Given this list of marker genes NPSR1, CXCL12, ATP6V0B, METTL21C, CP (ceruloplasmin), ATP6V1H, SLC4A7, CCDC22, EDN1, TMPRSS6, CASQ2, FTL, FTH1P19, SLC12A5, SLC30A5, SLC30A2, PTH1R (parathyroid hormone 1 receptor), BOLA1, ARF1, TM9SF4, CASQ1, LRRK2, CXCL9, ATP6V1A, CAV3, P2RX1, HTR2C, RGN, SLC39A10, WNK1 (NCBI Gene Id 9872), SLC4A1, CHRNA7, TMEM178A, MINPP1, EGLN1, PACS2, SLC26A3, THADA, SLC24A1, SLC4A4, SCNN1D, MAPK1, AQP11, NOL3 (nucleolar protein 3), SLC4A3, RNASEK, CHERP, CDH5, SLC4A2, ABL1, ABCB7, SCNN1G, MCOLN1, ITPR1 (inositol 1,4,5-trisphosphate receptor type 1), TUNAR, CCL21, CACNB4, HEPHL1, LIME1, GP1BA, ATP6AP1, FATE1, WBP2NL, DRD5, ANKRD9, CYBA, CLIC2, SPPL2C (NCBI Gene Id 162540), ATP13A1, BAX, EDNRA, BOLA3 (NCBI Gene Id 388962), RMDN3, VDR, PRKCE, TRPC7, CCR5, SLC39A14, ATP6V1B1, SLC9C1, FASLG, ANXA6, STEAP4, ABCB6, SLC1A1, TESMIN, ATP1A4, SCO2, FTMT, TMTC4, TPT1, ITPR3, PML, SMDT1, TGM2, SLC4A5, HTR2B, TTC7A, DRD1, XCL1, DRD3, GDF2, JPH2, KCNQ1, ATP2A3, NEO1, MYH7B, RYR3, RHCG, DMXL2, SCNN1A, IMMT, CLN6, VPS54, CAV2 (caveolin 2), BCL2, CCR1, MYC, MAPK3, RAB38, ADCY8, DHRS7C, GRINA, ATOX1, CEMIP, TFR2, SLC30A9, ATP5F1B, ATP2C1, MT2A, MECR, LETM1, PRKCB, KCTD17, NPPC, SLC4A11, HAMP, CACNA1C, MICU1, ERC2, CCDC47, CXCR3, CALB2, ATP4B, IREB2, ITPR2, DRD2, HERPUD1, TMEM38B, CCL7, IBTK, DMTN, SV2A, TNNI3, PDZD8, SLC10A7, DIAPH1, SLC39A4, SNCA, MT1DP, HEXB, TSPOAP1, UBE3A, AVPR1A, CFTR, STC2, C19orf12, CLN5, RYR2, ADORA1, CX3CL1, SELENOK, SLC39A12 (NCBI Gene Id 221074), MT1X, DMPK, APP, CISD1, GSTM2, TRPV4, RHAG, TMEM38A, CSRP3, SMAD5, ATP12A, BAK1, HMOX1, TMCO1, HAP1, PTPRC, FXYD2, CNGB1, HRC, HCRTR2, GP5, RAB7A, CAPN3, SLC9A5 (solute carrier family 9 member A5), CLIC4, LCN2, MIR210, SLC25A27, KCNMA1, CHP1, PPT1, GPER1, SLC39A8, PLCG2, ATP6V1F, CCL15, MICU3, CLCN3, FLVCR1, SLC39A9, YWHAE, LYN, TRPM7, UMOD, AFG3L2, ATP13A3, SLC40A1, ATP2B2, CCL13, SLC11A2, FBXL5, NDFIP1, SPNS1, SLC9B1, SCARA5, F2RL3, MIR93 (NCBI Gene Id 407050), CALCB, TRPM8, F2R, TMC8, MCUB, TBXAS1 (thromboxane A synthase 1), SLC24A2, FLNA, BOK, SOD1 (superoxide dismutase 1), CA2, GLRX5, ATP6V1D, RAB20, ACO1, GRID2IP, THY1, SLC45A2, ATP7A, ATP13A5, GRM5, FKBP1B, ATP2B4, BMP6, FXN, KCNE3, SMAD1, MIR1-1, MICU2, DMXL1, SLC12A2, HCRTR1, KEL, PLCB3, TRPC5, PIK3CB, PLCB4, CCR7 (C-C motif chemokine receptor 7), SLC46A1, TRPC6, SLC9A7, SRI, FRRS1, DMD, GPR12, CLN3, GHITM, SLC8B1, CASR, SELENON, ATP6V0D2, XCR1, TRPC1, WNT5A, CNNM4, GRIK2, VAPB, APOE, PTPN6, CALM3 (NCBI Gene Id 808), HSP90B1, JPH3, CCL8, P2RY6, GRN, SNAPIN (SNAP associated protein), MT1G, ATP2B1, CACNB2, AVP, SLC30A8, FZD9, PLCH1, ATP6V0A4, MT1F, ATP1A1, PRKD1, TPCN2, BOLA2, ATP1B3, PLCB2, ATP6V0D1, COX11, MT1A, CXCL11, CCL11, BNIP3, ERFE, OSBPL2, BDKRB1, ATP6AP2, SLAMF8 (NCBI Gene Id 56833), NTSR1, IFNG, SLC30A7, TMEM9, SLC4A10, SLC9A8, TGFB1, CREG1, ATP13A2, CHD7, CCL1, FTH1, NGF, PLCB1, UBASH3B, SCNN1B, PTH (parathyroid hormone), TMEM106B, PRNP, B2M, SLC9A4, NPY, CXCL10, ATP6V1G1, MCUR1, F2, MIR133A1, TRPM2, CALCA, ATG5, WNK4, CAV1, LETMD1, ATP2A2, RAP1GDS1, PLCG1, SLC39A6, SLC8A1, PLCL2, WFS1 (wolframin ER transmembrane glycoprotein), PDE4D, ATP2A1, NUBP1, EDN2, CLCC1, PICALM, LCK, GCM2, GRM1, STIM1, STIM2, HPX, SLC8A3, SV2B, DRD4, CCL5, JPH4, CALM2, XK, TRDN, ATP4A, TMC6, GSTO1, STEAP2, PLCH2, PTK2B, ATP7B, HVCN1, SYPL2, NPTN, CORO1A, SLC4A9, HTR2A, SLC31A1, AKAP6, CALB1, MCU, SLC24A5, GPR89B, ASPH, MT4, ATP1B1, TMPRSS3, CAMK2D, CCR2, ISCU, ATF4, CCL14, CALR, MT1M, ATP2C2, HJV, SCO1, PKHD1, SLC9A1, GPR89A, CALM1, TMEM175, LACC1, OCA2, SLC26A6, ANK2, IL1A, SLC39A13, ERO1A (endoplasmic reticulum oxidoreductase 1 alpha), CDH23, GLRX3, MT1H, ITGB3, TMBIM6, ALAS2, SLC9A9, CTRC, TCIRG1 (NCBI Gene Id 8845), SLC9A3, SLC39A5, SLC30A1, BOLA2B, SLC24A4, GP9, SLC25A23, LACRT, NCOA4, SMAD9, ATP6V1B2, SLC22A17, SLC8A2, TMEM64, AP3B1, ATP6V0A1, VPS33A, RAB39A, ATP1A2, FKBP1A, FTHL17, P2RY2, STOML2, ATP6V0A2, SLC1A3, TMEM94, STC1, TMEM165, SLC41A1, CYB561A3, ATP13A4, ATP6V0E1, PRND, IL13, HIF1A, MT3, SLC31A2, CD19, PRKACA, HFE, MAIP1 (NCBI Gene Id 79568), MT1B, JPH1, ATP6V0C, CYBRD1 (NCBI Gene Id 79901), CACNA1S, COX19, TRPA1, P2RX7, CCL3, ELANE, TMEM203, SLC9A2, CCDC115, PLN, CLDN16 (claudin 16), SLC39A7, EDN3, CD40, ATP6V0E2, ACVR2B (activin A receptor type 2B), SLC11A1, ATP2B3, CCL23, GP1BB, TASL, TRPC3, KCNK16, MT1E, TMEM199 (transmembrane protein 199), TF, TFRC, TRPC4, SLC24A3, APLNR (NCBI Gene Id 187), KCTD7, ATP1A3, SLC4A8, PLCE1, SLC9C2, ATP1B2, SMAD4, PSEN1, KCNJ2, HTT, MTLN, SLC30A10, PDPK1, DDIT3, CYB561, LAMP2, MT1HL1, DISC1, SLC35G1, CNR1, CCL19, LAMP1, STK39 (NCBI Gene Id 27347), CA7, FGF2, PLCL1, PKD2, SLC9A6, RYR1, P2RY1, here is a description of the gene set: species: Homo sapiens Human Gene Set: GOBP_INTRACELLULAR_MONOATOMIC_ION_HOMEOSTASIS A homeostatic process involved in the maintenance of a steady state level of monoatomic ions within a cell. Monatomic ions (also called simple ions) are ions consisting of exactly one atom.